The following is a description of a gene set: Any process that results in a change in state or activity of a cell (in terms of movement, secretion, enzyme production, gene expression, etc.) as a result of X-ray radiation. An X-ray is a form of electromagnetic radiation with a wavelength in the range of 10 nanometers to 100 picometers (corresponding to frequencies in the range 30 PHz to 3 EHz). species: Mus musculus Mouse Gene Set: GOBP_CELLULAR_RESPONSE_TO_X_RAY, and this is the list of marker genes: Trp53bp1, Xrcc5, Gata3, Nipbl, Ccnd2, Nucks1, Atm, Prap1, Sfrp2, Xrcc6, Sfrp1